Given this list of marker genes GDE1, GDPD4, ENPP6, GDPD5, GDPD2, here is a description of the gene set: Human Gene Set: GOMF_GLYCEROPHOSPHODIESTER_PHOSPHODIESTERASE_ACTIVITY species: Homo sapiens Catalysis of the reaction: a glycerophosphodiester + H2O = an alcohol + sn-glycerol 3-phosphate.